The following is a description of a gene set: Human Gene Set: REACTOME_AGGREPHAGY Aggrephagy species: Homo sapiens, and this is the list of marker genes: VIM, TUBA4A (tubulin alpha 4a), TUBA3C, DYNC1LI2, RPS27A, CETN1, DYNLL2, TUBB3, TUBA3E, TUBA1B, PRKN, VCP, PARK7, IFT88, TUBAL3, TUBB8 (NCBI Gene Id 347688), TUBB2B, HSP90AA1, ARL13B (NCBI Gene Id 200894), PCNT, UBA52, TUBB4A, TUBA3D, DYNC1LI1, DYNC1I1, HSF1, UBB, TUBB2A, TUBA4B, TUBB1, TUBB6, CFTR, TUBA1A, TUBA1C, HDAC6, TUBA8, DYNC1I2, DYNC1H1, DYNLL1, UBE2V1, UBC, UBE2N, TUBB8B, TUBB4B